The following is a description of a gene set: Pain in head and neck region studied in species Homo sapiens Human Gene Set: HP_PAIN_IN_HEAD_AND_NECK_REGION, and this is the list of marker genes: KRT6B, KRT6A, TCF4, RASA1, TERT, NTRK1, NF2, COL17A1, SLC39A14, KRT17, SF3B1, TACSTD2, AKT1, TRAF7, VSX1, PIK3CA, ZEB1, SCN9A, BAP1, KRT16, COL8A2, PDGFB, CYSLTR2, DKK1, CTNS, HTRA1, TGFBI, SUFU, CHST6, GDF3, TONSL, AGBL1, MEOX1, HMBS (hydroxymethylbilane synthase), SMARCE1 (SWI/SNF related, matrix associated, actin dependent regulator of chromatin, subfamily e, member 1), GNAQ, GRHL2, SLC4A11, GDF6, OVOL2, SMARCB1, SMO, GNA11